Given this list of marker genes RPS2, EPN2, SPTAN1, RPL7A, CDH6, CDH3, CDH10, H3C6, UBAP2, EIF2S3, LRRFIP1, LYPLA2, CDH11, PRDX1, PKP2, EHD1, PUF60, RPL15, CTNNA1, PDLIM5, CCT8, STXBP6, EIF4G2, PPFIBP1, H3C11, YWHAE, ABI1 (abl interactor 1), GIPC1, PRDX6, DAB2IP, MAPRE1, EZR, H3C7, TES, RSL1D1, LDHA, YWHAB (tyrosine 3-monooxygenase/tryptophan 5-monooxygenase activation protein beta), TWF2, TRIM29, H3C12, BAG3, DDX3X, SH3GLB1, HSP90AB1, ARHGAP18, RPL29, USO1, PTPRO, TLN1, ATXN2L, BMPR2, LIMA1, PKN2, OLA1, NHERF2, RTN4, UNC45A, CDH8, CNN3, GOLGA3, WASF2, PTPRH, YWHAZ, DCHS1, CDH19, FNBP1L, KRT18, RPL6, EIF4H, RPL24, ERC1 (NCBI Gene Id 84770), PPP1R13L, IST1, PKM, SNX9, ARHGEF16, CRKL, KDR, EPS8L2, MB21D2, ANXA2, MYO1B, ITGA6, YKT6, PPP1CA, RPL14, CNN2, CEMIP2, RACK1, BAIAP2L1, CTNNA3, TRIM25, TMOD3, PSMB6, RPL23A, GPRC5A, PARK7, RPS26, CTNNB1, TXNDC9, PAK4, TNKS1BP1, CDH2, H3C1, CHMP5, RANBP1, STK38, SEPTIN2, HSPA8, NIBAN2, SNX5, CDH1, PTPRT, AFDN, SEPTIN9, VCL, EPS15, AHNAK, TRPC4, EIF3E, CLIC1, MARK2 (microtubule affinity regulating kinase 2), SRC, EIF5, CGN, NEO1, TBC1D2, DDX6, PTPRB (protein tyrosine phosphatase receptor type B), CLINT1, FSCN1 (fascin actin-bundling protein 1), NUDC, GAPVD1, TJP1, PPME1, CTTN, CORO1B, RAB1A, PI4KA, PDXDC1 (NCBI Gene Id 23042), DHX29, CDH17, PAK2, COBLL1, ANXA1, RDX, H3C3, ZC3HAV1, PACSIN2, CAPG, PLCB3, LARP1, RAN, FLNA, H3C8, PFKP, PSEN1, NOP56, BZW2, ARFIP2, SPTBN1, EEF1D, VASN, MRTFB, PTPRM, FMNL2, CTNND2, USP8 (ubiquitin specific peptidase 8), PAK6, RUVBL1, CDH26, CD2AP (NCBI Gene Id 25916), SHTN1, BAIAP2, DOCK9, CDH15 (NCBI Gene Id 1013), CALD1, BZW1, CDK5R1, DIAPH3, CTNNA2, ENO1 (NCBI Gene Id 81977), ALDOA, APC, EPS8L1, PARVA, RARS1, PCMT1, CDH5, ABCF3, P2RX4, MPP7, PHLDB2, DBN1, VASP, MACF1, NCK1, GCN1, GLOD4, HCFC1, ITGB1, CDH23, JUP, CD46, SLC3A2, DBNL, ZC3H15, CDH7, VAPB, PTPRJ, ATIC, STK24, BSG, LRRC59, NUMB, PROM1, CCS, OLFM4, EMD, ADD1, RAB10, CDH24 (cadherin 24), RAB11B, HDLBP, LAD1, CAPZA1, CDH12, ANLN, SLK, PLEC, KTN1, SH3GL1, MICALL1, SEPTIN7, PICALM, CDHR3, MRE11, H1-10, GOLGA2, CDH20, RPL34, DLG1, HNRNPK, FXYD5, SNX1, CDH18, CNGA3, H3C10, CAPZB (capping actin protein of muscle Z-line subunit beta), CSNK1D, CC2D1A, EEF1G, MYH9, IDH1, SERBP1, FLNB, S100P (S100 calcium binding protein P), VAPA, MMP24, ARGLU1, EPS15L1, DNAJB1, KIF5B, NOTCH3, HSPA1A, PDLIM1, TJP2, ANK3, NDRG1, CIP2A, SWAP70, ARHGAP1, SPTBN2, EPCAM, SND1, PPL (NCBI Gene Id 5493), CDH4, PKP1, EPHA2, HSPA5, SH3GLB2, PCBP1, S100A11, EHD4, F11R, IQGAP1, PTPN1, SCYL1, EGFR, CTNNAL1, RANGAP1, ARVCF, SNX2, KLC2, PKP3, H3C2, ESYT2, SFN, TWF1 (twinfilin actin binding protein 1), EVPL, CDH13, STAT1, FASN (NCBI Gene Id 2194), TMPO, AHSA1, TBC1D10A, PTPN11, EXOC3, CBL, EFHD2, ACVR1, CHMP2B, PFN1, STX5, EIF2A, PAICS, PLIN3, CAST, H3C4, ASAP1, TAGLN2, MPRIP, CDH9, CKAP5, CDC42EP1 (CDC42 effector protein 1), SCRIB, EEF2, CHMP4B, CTNND1, CDH22, GIGYF2, PKP4, LASP1, CCNB2, UBFD1, here is a description of the gene set: species: Homo sapiens Binding to cadherin, a type I membrane protein involved in cell adhesion. Human Gene Set: GOMF_CADHERIN_BINDING